Given this list of marker genes NFU1, SV2A, CNP, CACNA1G, SLC25A12, GFM2, SDHD, TBCK, SDHAF1, GRM7, GALC, FBXO28, NAT8L, ATAD3A, NGLY1, GCSH, NDUFB7, PSAP, here is a description of the gene set: species: Homo sapiens Human Gene Set: HP_REDUCED_BRAIN_N_ACETYL_ASPARTATE_LEVEL_BY_MRS A decrease in the level of N-acetyl aspartate in the brain identified by magnetic resonance spectroscopy (MRS). Reduced brain N-acetyl aspartate level by MRS